The following is a description of a gene set: species: Homo sapiens Abnormality of the metopic suture The frontal suture divides the two halves of the frontal bone of the skull in infants and children and generally undergoes fusion by the age of six. A persistent frontal suture is referred to as a \metopic suture\. Human Gene Set: HP_ABNORMALITY_OF_THE_METOPIC_SUTURE, and this is the list of marker genes: WDR35, CDK8, ALG9, PDX1, KDM4B, FBXL4, NUP188, KCNQ1OT1, GLI3, FGFR1, PTCH1, PPP2R1A, GPC3, ERMARD, TOGARAM1, STAT3, KCNQ1, KDM5B, CDC6, SLC4A10, TBCK, RAB23, ADARB1, KANSL1 (KAT8 regulatory NSL complex subunit 1), GCK, SIX2, STXBP1, CRELD1, SON, POLR1A, MAPK1 (NCBI Gene Id 5594), MAF, RTTN, ZNF292, DIAPH1, CAMSAP1, MSX2, RNU4-2, NSRP1, GJA5, HNRNPK, INS, FOXG1, OTUD5, IFT140, ADSL, ACTG1, FGFR2, MID1, SMG9, RNU4ATAC, MAP1B, HERC1, HNRNPU, PCDHGC4, GPC4, ASXL3, SETBP1, INTU, CDKN1C, LMX1B, GNPTAB, FREM1, IL11RA, ERCC1, ASXL1 (NCBI Gene Id 23393), DDB1, UBAP2L, TWIST1, PIGA, ABCC8, H3-3B (H3.3 histone B), ZNF462, ACTB, ERCC2, SMARCD1, FBXO11, PIGT, NOTCH3, ERCC6, PURA, EBF3, NAA10, MEGF8, KCNJ11, SC5D, GJA8, ADAMTSL1, NFIA, IGF2, ERCC5, ERF, TMEM216, NARS2, PPFIBP1, ATIC, CLCN3, SRCAP